Given this list of marker genes MACF1, FOXN3, MSANTD4, ELAVL2, AKAP17A, MERTK, KIF5C, MKI67, GAP43, C3orf62, NCAPG, ADAT2, TPGS2 (NCBI Gene Id 25941), UBE2B, ANKRD37, GALC, PLXNA4, NCAM1, IDS (iduronate 2-sulfatase), ETNPPL, ASXL2, MAB21L2, RASGRF2, PLCH1, CNOT2, MAD2L2, ANKRD49 (NCBI Gene Id 54851), PHC3, PITPNA, PHIP, PIP4K2B, LINGO2, DBNDD2, TNRC6B, LRP6, RICTOR, SP8, SPRTN, SLC41A1, RASGRF1, C11orf24, SNAI2, RDX, SAP130, SLC13A3, PHACTR2, WDR36, MTHFD2, BCL9, DCPS, POU2F1, MESP2, GPR162, EML4, ZBBX, WNK3, YY1, VSTM2A, FAM171A1 (NCBI Gene Id 90061), AP3M1, PCP4L1, ALPK3, RASD1, BACH2, SLC19A4P, RGS8, NRXN3, TRAF3, here is a description of the gene set: Genes predicted to be targets of miRBase v22 microRNA hsa-miR-3614-5p in miRDB v6.0 with MirTarget v4 prediction scores > 80 (high confidence targets). species: Homo sapiens from publication Chen Y, Wang X (PMID 31504780) Human Gene Set: MIR3614_5P